Given this list of marker genes CYP19A1, SERPINE2, GYPB, LIMS1, AGPAT1, DCTD, LRRFIP2 (NCBI Gene Id 9209), PPOX, UBE2N, EPHA1, EGFR, FAN1 (FANCD2 and FANCI associated nuclease 1), EGR1, PPP1R12C, FGF2, here is a description of the gene set: from publication Kyng KJ, May A, Stevnsner T, Becker KG, Kølvrå S, Bohr VA (PMID 15897889) The accumulation of DNA damage and mutations is considered a major cause of cancer and aging. While it is known that DNA damage can affect changes in gene expression, transcriptional regulation after DNA damage is poorly understood. We characterized the expression of genes in human primary fibroblasts after exposure to three different kinds of cellular stress that introduces DNA damage: 4-nitroquinoline-1-oxide (4NQO), gamma-irradiation, or UV-irradiation. Each type of stress elicited damage specific gene expression changes of up to 10-fold. A total of genes had similar changes in expression of 3-40-fold after all three kinds of stress. We examined transcription in cells from young and old individuals and from patients with Werner syndrome (WS), a segmental progeroid condition with a high incidence of cancer, and found various age-associated transcriptional changes depending upon the type of cellular stress. Compared to young individuals, both WS and old individuals had similarly aberrant transcriptional responses to gamma- and UV-irradiation, suggesting a role for Werner protein in stress-induced gene expression. Our results suggest that aberrant DNA damage-induced gene regulation may contribute to the aging process and the premature aging in WS Genes responding to 4NQO treatment and gamma irradiation. studied in species Homo sapiens Human Gene Set: KYNG_DNA_DAMAGE_BY_4NQO_OR_GAMMA_RADIATION